The following is a description of a gene set: Regulation of MITF-M-dependent genes involved in lysosome biogenesis and autophagy Human Gene Set: REACTOME_REGULATION_OF_MITF_M_DEPENDENT_GENES_INVOLVED_IN_LYSOSOME_BIOGENESIS_AND_AUTOPHAGY species: Homo sapiens, and this is the list of marker genes: ATP6V1F, ATP6V0A1, ATP6V1B2, ATP6V1D, ATP6V0C, ATP6V1E1, ATP6AP2 (ATPase H+ transporting accessory protein 2), ATP6V1A, ATP6V0E2, ATP6V1C1, ASAH1 (NCBI Gene Id 79795), ATP6V0E1, MITF, ATP6V1H, ATP6V1G1, ATP6V0D1, ATP6V0B